Given this list of marker genes CEP162, ARHGEF5, SP8, CYP17A1, C5orf15, AFF1, here is a description of the gene set: studied in species Homo sapiens from publication Chen Y, Wang X (PMID 31504780) Genes predicted to be targets of miRBase v22 microRNA hsa-miR-25-5p in miRDB v6.0 with MirTarget v4 prediction scores > 80 (high confidence targets). Human Gene Set: MIR25_5P